Given this list of marker genes BAK1, OPN3, TIPIN, CASP7, BRSK1, COL6A2, UBE2A, MMP2, HYAL2, POLD3, HMGN1, CCAR2, TAF1 (NCBI Gene Id 6872), MAPK11, TREX1, AKT1, PCNA, SERPINB13, TP53, ZBTB1, TMEM161A (transmembrane protein 161A), ERCC1, EIF2AK4, PRIMPOL, HYAL3, DCUN1D3, FBXW7, USF1, INO80, CAT, RPL26, BCL2, ATF4 (activating transcription factor 4), IL12A, POLA1, RELA, COPS9, POLH, MDM2, PIERCE1, ELANE, XPA, BCL3, PARP1, STK11, COL6A3, NFATC4, PCLAF (NCBI Gene Id 9768), CDKN2D, WRN, BAX, NEDD4, FEN1, SCARA3, MAPK8, CERS1, MFAP4, POLK, TYR, UBE4B, RHNO1, COL6A1, ZRANB3, AURKB, MC1R, ERCC6, PPID, PBK, RBX1 (ring-box 1), IL12B, REV1, MAP4K3, ACTR5, MMP1, ATR, ERCC5, TP53I13, CIRBP, FECH, AQP1, RPAIN (RPA interacting protein), CRIP1, MAP3K4, H2AC25, PTPRK, NLRP1, SIRT6, PRKCD, MAP2K7, SMPD1, MSH6, METTL3, SPRTN, OPN1SW, USP1, CRYAA, EIF2S1, EGFR, MMP3, CDKN1A, CUL4A, YY1, BRCA2, TP53INP1, ST20, PIK3R1, OPN5, MMP9, GPX1, HUS1, CUL4B, MAP3K20, TRIM32, DDB1, NOC2L, PML, EP300, HYAL1, USP28, ERCC3, GNAT2, UBE2B, DDB2, MAPK14, MYC, BMF, MME, CCND1, CREBBP, MAPK13, DHX36, GTF2H2, TIMP1, RO60, IVL, XPC, ERCC2, RUVBL2, ERCC4, RHBDD1, ERCC8, NSMCE3, DTL, KDM1A, POLD1, MEN1, CASP3, NPM1 (nucleophosmin 1), UVSSA, MSH2, PRKAA1, SDE2, N4BP1, SDF4, TRIAP1, CASP9, SIRT1, EI24, here is a description of the gene set: studied in species Homo sapiens Any process that results in a change in state or activity of a cell or an organism (in terms of movement, secretion, enzyme production, gene expression, etc.) as a result of an ultraviolet radiation (UV light) stimulus. Ultraviolet radiation is electromagnetic radiation with a wavelength in the range of 10 to 380 nanometers. Human Gene Set: GOBP_RESPONSE_TO_UV